Given this list of marker genes MOAP1, GSK3A, TRIM23, UFL1, NUPR1, LEP, TBC1D25, WDR24, TFEB, LAMP3, PIP4K2A, FYCO1, ORMDL3, DAPK2, ATP6V0B, ATP6V0A1, ATP6V1A, SMCR8, LRRK2, TPCN1, CAPN1, UVRAG, PLK3, ACER2, DELE1, EIF4G3 (eukaryotic translation initiation factor 4 gamma 3), FOXK2, SVIP, ZKSCAN3, HSPB8, KDM4A, LRSAM1, GAPDH, ERCC4, MAGEA6, CSNK2A1, CTTN, ZC3H12A, EXOC8, TBK1, BAG3, MUL1, GATA4, CISD2, ENDOG (NCBI Gene Id 2021), VPS26B (VPS26 retromer complex component B), BCL2L1, RRAGB, MTCL3, MID2, RUFY4, UBQLN1, PTPN22, ATP6V1G1, STAT3, MTMR9, RRAGC, GOLGA2, PIK3R4 (phosphoinositide-3-kinase regulatory subunit 4), ATG16L1, TLR9, DEPDC5, STK11, FBXO7, HMOX1 (NCBI Gene Id 3162), EPM2A, HERC1, HMGB1, FZD5, AKT1, DRAM2, ABL2, NOD1, MAGEA3, BECN1, PLK2, UBE2A, BNIP3L, MAP2K1, GSK3B, WAC, EP300, SETD2, KDR, HSPB1, DAPK1, RNF31, ATP6V1C1, CALCOCO2, AMBRA1, PIP4K2C, ERFE, PAFAH1B2, GPR137, TAB3, MIR199A1, ATP6V1E2, RPGR, VPS13D, ATP6V1E1, DRAM1, QSOX1, ATG12, PLEKHF1, TICAM1, RB1CC1, DCN, PRKAA1 (protein kinase AMP-activated catalytic subunit alpha 1), CPTP, RRAGD, MTCL2, NEDD4, RUBCN, KLHL22, MCL1, MAP3K7 (NCBI Gene Id 6885), PPTC7 (protein phosphatase targeting COQ7), DAPK3, TPCN2, FOXK1, SNX30, MFSD8, DDRGK1, NPRL3, FBXW7, ATP6V0D2, ATP6V0C, GFAP, CRYBA1, TRIM22, PIK3C2A, ATP6V0D1, SREBF2, VHL, STING1 (stimulator of interferon response cGAMP interactor 1), STUB1, SLC35D3, PIK3CB, FKBP8, SLC25A5, KAT8, NLRP6, TRIM32, ABL1, NRBP2, HUWE1, PIK3C3, GNAI3, TSC2, USP30, SH3GLB1, VPS26A, CDK5, ELAVL1, XBP1, FOXO3, RIPK2, ADRB2, TRIM65, USP36, EHMT2, TP53INP1, RNF152, EIF4G2, TRIM21, EIF4E, WDR45, ATP6V0A2, BAD, TOMM7, UBR4, PIK3CA, ADCY10, EXOC1, ZDHHC19, RNF5, GPR137B, OPTN, CSNK2A2, SNRNP70, GPSM1, TP53, ATP6V1B2, ATP6V0E2, EXOC4, IRGQ, ATM, CAPNS1, RHEB, KAT5, HTRA2, MAPK15, SPTLC1, CDK16, ERN1, SUPT5H, PYCARD, ATF6, CDK5R1, PINK1, TECPR1, ATG5, DEPTOR, FBXL2, FOXO1, ZMPSTE24, XPA, PARL, EXOC7, DEPP1, HIF1A, ATP6V1C2 (NCBI Gene Id 245973), SNX32, WIPI1, ULK1, SREBF1, SLC7A5, BMF, PRKACA, RAB8A, PRKN, POLDIP2, TOM1, USP13, MTM1, OSBPL7, DNM1L, PIM2, IL10RA (NCBI Gene Id 3587), EIF2AK1, SEC22B, MTCL1, USP10, TRIM27, RASIP1, SLC25A4, MET, HDAC6, DAP, DHRSX, BNIP3, NPRL2, EEF1A2, MTMR8, ULK2, SNX7, VPS13C, KEAP1, WASHC1, UCHL1, ATP6V1G2, PHF23, CDK5RAP3, PRKAA2, WDR6, DDIT3, ATP6V1B1, RPTOR, SCFD1, PSAP, RAB3GAP1, TRIM8, C9orf72, SNCA, CCNY, IFNB1, TIGAR, CDC37, PIK3R2, LACRT, GBA1, VPS35 (VPS35 retromer complex component), SESN1, BCL2, TAB2, IKBKG, MTDH, IRGM, SNX5, SESN2 (sestrin 2), ATG13, LZTS1, ULK3, NOD2, TLK2, CAMKK2, WDR41, SPTLC2, CERS1, SCOC, IL10, NPC1, MAPK8, ELAPOR1, RAB37, ROCK1, USP33, PIP4K2B (NCBI Gene Id 8396), RBX1, CLEC16A, ATG14, UBQLN4, MAPT, TMEM39A, USP20, HK2, STK38L, ATP6V1D (NCBI Gene Id 51382), MTOR, FEZ2, ATP13A2, DAPL1, CASP3, MEFV, EEF1A1, PARK7 (Parkinsonism associated deglycase), SH3BP4, CTSA, SNX4, EIF4G1, LARP1, NAT8B, MAPK3, ATG2A, ATP5IF1, IL4 (interleukin 4), SNX6 (NCBI Gene Id 58533), VDAC1, ATP6V0E1, RNF41, FEZ1 (NCBI Gene Id 9638), WNK1, TRIM13, SIRT2, IFNG, ADRA1A, CISD1, TREM2, UBQLN2, FBXL4, SQSTM1, TBC1D14, PRKD1, LYPLA1, HAX1, DCAF12, VPS29, RMC1, ATG101, RAB3GAP2, SNX18, HTT, RAB39B, ITPR1, LEPR, TSPO, FLCN, MLST8, BOK, RALB, ATP6V1H, TRIB3, SIRT1, RRAGA, SESN3, TMEM59, IFI16, CLN3, TSC1, HGF, KIF25, here is a description of the gene set: Human Gene Set: GOBP_REGULATION_OF_AUTOPHAGY Any process that modulates the frequency, rate or extent of autophagy. Autophagy is the process in which cells digest parts of their own cytoplasm. species: Homo sapiens